The following is a description of a gene set: from publication Chen Y, Wang X (PMID 31504780) Human Gene Set: MIR518A_3P_MIR518B_MIR518C_3P_MIR518D_3P_MIR518F_3P_MIR526A_3P Genes predicted to be targets of miRBase v22 microRNA hsa-miR-518a-3p, hsa-miR-518b, hsa-miR-518c-3p, hsa-miR-518d-3p, hsa-miR-518f-3p, hsa-miR-526a-3p in miRDB v6.0 with MirTarget v4 prediction scores > 80 (high confidence targets). species: Homo sapiens, and this is the list of marker genes: TSN, NDUFA4, ZNF282, FBXO3, TEAD3, ZNF281, ATXN7L3, EGR1